Given this list of marker genes Ndst2, Ext1, Slc35d2, Tm9sf2, Xylt2, Extl3, Hs2st1 (heparan sulfate 2-O-sulfotransferase 1), B3galt6, Ext2, Tcf7l2, Hs3st3a1, Hs6st3, Ndst1, Dse, Hs3st6, Lipc, Ndst3, Ugdh, Hs3st3b1, Hs3st1, Extl1, Hs3st4, Ctnnb1, Hs6st1, Vangl2, Pxylp1, B3gat3, Glce, Hs3st5, Hs3st2, Xylt1, Hs6st2, Ndst4, here is a description of the gene set: Mouse Gene Set: GOBP_HEPARAN_SULFATE_PROTEOGLYCAN_BIOSYNTHETIC_PROCESS The chemical reactions and pathways resulting in the formation of heparan sulfate proteoglycans, which consist of a core protein linked to a heparan sulfate glycosaminoglycan. The heparan sulfate chain is composed of the repeating disaccharide unit beta-(1,4)-N-acetyl-D-glucosamine-alpha-(1,4)-hexuronic acid, the former being either sulfated or deacetylated on its amino group as well as sulfated on one of its hydroxyl groups, and the latter being e a mixture of sulfated and nonsulfated D-glucuronic and L-iduronic acids. Heparan sulfate chains are covalently linked to serine/threonine residues (O-linked) of the core protein via a tetrasaccharide linker sequence (xylose-galactose-galactose-glucuronate). studied in species Mus musculus